Given this list of marker genes PARK7, CFTR, SLC26A3 (solute carrier family 26 member 3), SOD2, KCNC2, TRPC5, AGT, KCTD7, HCN1, CRTC1, KCNQ3, KCNA5, CACNG2, here is a description of the gene set: The process in which membrane potential increases with respect to its steady-state potential, usually from negative potential to a more negative potential. For example, during the repolarization phase of an action potential the membrane potential often becomes more negative or hyperpolarized before returning to the steady-state resting potential. Human Gene Set: GOBP_MEMBRANE_HYPERPOLARIZATION studied in species Homo sapiens